Given this list of marker genes Sult2a7, Sult2a2, Sult2a6, Slc5a5, Pax8, Tg, Hpn, Foxe1, Ctsb, Sult1b1, Gcnt4, Ctns, Crym, Dio3, Slc16a2, Sult2a8, Gata3 (NCBI Gene Id 14462), Sult2a3, Duoxa1, Sult1a1, Slc26a7, Dio1, Cga, Ctsk, Kcnj6 (potassium inwardly-rectifying channel, subfamily J, member 6), Slc16a10, Iyd, Ctsl, Sult2a4, Tpo (NCBI Gene Id 22018), Sult2a1, Cpq, Duoxa2, Sult2a5, Duox2 (NCBI Gene Id 279020), Reln, Slco1c1, Dio2, Med1, Slco4a1, here is a description of the gene set: The chemical reactions and pathways involving any of the compounds secreted by the thyroid gland, largely thyroxine and triiodothyronine. studied in species Mus musculus Mouse Gene Set: GOBP_THYROID_HORMONE_METABOLIC_PROCESS